The following is a description of a gene set: The chemical reactions and pathways resulting in the breakdown of dermatan sulfate proteoglycans, which consist of a core protein linked to a dermatan sulfate glycosaminoglycan. The dermatan sulfate chain is composed of the repeating disaccharide unit beta-(1,4)-D-hexuronic acid-beta-(1,3)-N-acetyl-D-galactosamine. The former can be a mixture of sulfated and nonsulfated D-glucuronic and L-iduronic acids and the latter can be O-sulfated. studied in species Mus musculus Mouse Gene Set: GOBP_DERMATAN_SULFATE_PROTEOGLYCAN_CATABOLIC_PROCESS, and this is the list of marker genes: Ids, Hexb, Hexa, Idua, Arsb